The following is a description of a gene set: Abnormal esophagus morphology Human Gene Set: HP_ABNORMAL_ESOPHAGUS_MORPHOLOGY species: Homo sapiens A structural abnormality of the esophagus., and this is the list of marker genes: TYMS, CYBB, NOP10, BLM, PSPH, FANCI, MED12, SMAD3, UBA2, PHKG2, VPS37D, TGFB3, CBS, GTF2IRD1, IFT80, ZIC3, WWOX, FOXF1, COL14A1, GBA1, PDE11A, TNPO3, ZFX, TINF2, SEMA3E, PROKR2, SMARCD1, WNT7A, EFTUD2, PLA2G4A, ATAD1, ADA2 (NCBI Gene Id 51816), GNB2, IRF5, DLL4, ATP7B, DOCK6, FANCA, FANCG, DLEC1, TERC, RAD21, FGFR2, ADAMTSL2, CARD8, CYBA, ENG, NCF4, KRT18 (keratin 18), GTF2I, SLC2A10, ITGB4, TCF4, ARHGAP31, ELN, POT1, STX1A, F5, DCLRE1B, FBN2 (fibrillin 2), TCOF1, SCAF4, BAZ1B, ALMS1, DOCK8, LMBRD1, RNF6, PAICS (NCBI Gene Id 647765), SDHB, MYCN, NCF2, IL12RB1, BUD23, PRKAR1A, DKC1, MALT1, IFT56, REL, FKBP6, GBE1, KIT, JAK2, TRAPPC11, LAMA3, SLX4, DYNC2I1, TERT, EIF4H, ADAMTS2 (NCBI Gene Id 9509), NOTCH1, OTX2, POU2AF1, FANCE, MAD2L2, GTF2IRD2, LZTS1, TBL2, NOTCH3, AR, FANCM, ASCC1 (NCBI Gene Id 51008), METTL27 (methyltransferase like 27), LAMB3, PARN, PAH, MID1, LIPA, STAT1 (NCBI Gene Id 6772), SALL1, SDHC, COL4A6, INTU, GREB1L, TNFSF15, IL12A, FH, GLRB, MMP1, PDGFRA, PKHD1, FARSB, IKZF1, MEN1, FANCF, BRIP1, CYBC1, UBE2T, DNAJC30, STAT6, MYH11, SAMD9, KIF3B, ELF4, RPL11, CLIP2, WNT9B, BRCA2, GFRA1, GRB10, POLR1D, SIX6, PHGDH, GIMAP5 (GTPase, IMAP family member 5), MSR1, TGFB1, ITGA6, AAGAB (NCBI Gene Id 79719), CARMIL2, SLC30A10, TMEM67, COL4A5 (collagen type IV alpha 5 chain), IARS1, BRCA1, DZIP1L, WBP11, USB1, STXBP1, NHP2, FANCB, ATP7A, POLR1B, BRAF, RTEL1, PLEC, DSG1 (NCBI Gene Id 1828), XRCC2, RAD51, POLR1C (NCBI Gene Id 9533), ITGA8, SLC6A5, SOX2, FERMT1, MAMLD1, ERCC4, YY1, DCDC2, SDHA, FGF20, KIF12, SPIB, CEP295, CHD7, GRHL2, RFC2, CDKN1B (NCBI Gene Id 1027, cyclin dependent kinase inhibitor 1B), STK11, FANCC, DYNC2I2, FGFR1, NPM1, CTHRC1, GDF2, ACD, NCF1, GPHN, TGFBR1, PHKA2, LIMK1, ACVRL1, COG6, PGM3, ARNT2, FANCD2, HLA-B, STN1, WDR35, LMX1B, RHBDF2, PALB2 (NCBI Gene Id 79728), DCC, GLRA1, SMAD4, SLC12A2, CTC1 (CST telomere replication complex component 1), CALR, DYNC2H1, TMEM270, FANCL, TGFBR2 (NCBI Gene Id 7048), RBPJ, RMRP, DGUOK, RAD51C, HESX1, RFWD3, LAMC2, HOXD13, POLA1, PDGFRB, APC, MMEL1, GMPPA, EOGT, WRAP53, SOX3, STAT3, TGFB2, COL7A1, RET